The following is a description of a gene set: LDLRAD4 and what we know about it studied in species Homo sapiens Human Gene Set: WP_LDLRAD4_AND_WHAT_WE_KNOW_ABOUT_IT, and this is the list of marker genes: ATG16L1, SMAD2, TGFBR1, NEDD4, LDLRAD4, LDLRAD4-AS1, PMEPA1, TGFBR2